The following is a description of a gene set: Binding to one or more specific sites on an immunoglobulin receptor molecule. species: Mus musculus Mouse Gene Set: GOMF_IMMUNOGLOBULIN_RECEPTOR_BINDING, and this is the list of marker genes: Jchain, Adam8, Ighg2c, Ighm, Fcgr3, Lgals3, Tarm1, Clec4d, Flna, Adam15 (ADAM metallopeptidase domain 15), Cr2, Ighg2b, Fgr, Ighg1, Ighg3, Igha, Ighe, Adam28, Fes